Given this list of marker genes Ptn, Plau, Xbp1, Ifng, Cflar, Mdk, Hpn (NCBI Gene Id 15451), Ceacam1 (CEA cell adhesion molecule 1), Sulf2, Lims2, Fgf1, Cdkn2a, Lims1, Med1, Tnfaip3, Il18, Ceacam2, Rtn4, Tnf, Fgf18, Wnt3a, Cpb2 (NCBI Gene Id 93820), Gli1, Itpr1, Smo, here is a description of the gene set: Any process that modulates the frequency, rate or extent of hepatocyte proliferation. Mouse Gene Set: GOBP_REGULATION_OF_HEPATOCYTE_PROLIFERATION species: Mus musculus